The following is a description of a gene set: Binding to a melanocortin receptor. studied in species Mus musculus Mouse Gene Set: GOMF_MELANOCORTIN_RECEPTOR_BINDING, and this is the list of marker genes: Mrap2, Agrp, a, Mrap, Pomc